Given this list of marker genes ULK1, CRLS1, MIPOL1, STRADB, TBC1D4, BMI1, KDM7A, CLTRN, IL1R1 (interleukin 1 receptor type 1, NCBI Gene Id 3554), CHM, FNTB, CA13, FOXJ3, CCR5, GALNT7, ATAD2B, CHORDC1, TET3, C2CD4A, KCNN3, PSD3, RAD52, IRF2BP2, LARP1, SLC2A3, PPP1R3D, ATOSB, BAG4, LNX2, SRGAP1, LMO3, OVOL2, CRCP, NSMCE2, MEAF6, UNC80, DICER1, PDE4B, STXBP5L, ZNF689, DHX35, RFESD, FRMD3, FA2H, CAPZA2, PALM3, MYPN, ATP2B1 (ATPase plasma membrane Ca2+ transporting 1), SEMA6D, PPP6R3, KLF7, SKIL, PAQR8, EML4, SIX4, OLIG3, EIF2S1, MLANA, ZNF532, MAGEE1, FERMT2, NCAM2, C12orf76, GJA1, DSN1, FUBP3, PSMA2, ESRP1, CREBL2, RFK, ZNF449, GPR171, DBF4, PGM2, DAB2, TMEM245, WDR26, PLEKHG1, YPEL2 (NCBI Gene Id 388403), SARAF (store-operated calcium entry associated regulatory factor), TENT4B, C5, ODC1, SKP2, TTC13, POLR2M, KDM6A, ZNF518A, PALM2AKAP2, MARCHF4, CREB1, STK39, U2SURP, SKI (SKI proto-oncogene), GSK3B, PHF6, PHF3, FAM200B, ETNK1 (NCBI Gene Id 55500), NAP1L3, MRFAP1, NOSTRIN, TMEM69, PTPN1, KIF5B, FAM98A, FAR1, TAFA2, KLHL18 (NCBI Gene Id 80077), GABRG2, BACH2, RAB28, LEP, YWHAG, TRABD2A, CIPC, SPIN4, DCLK1, CREBRF, RTN3, LRRC8C, AAK1, RHOQ, SYNPO2, RCBTB1, CUL4B, DENND4C, OSBPL11, REEP3, USF3, PRKAG2, DCBLD2, PLD5, PRTG, CDK6, RALA, ITSN1 (intersectin 1), FLVCR1, GCOM1, LPCAT2, FBN1, RSPH4A, KLHL42, EP300, DUSP4, MAPK6, NCOA1, PABIR1, PDE4DIP, CHD1, ZDHHC6 (NCBI Gene Id 64429), BEST3, RALGAPB, TET2, TRPC3, ZNF652, CD2AP, TFRC, SREK1 (splicing regulatory glutamic acid and lysine rich protein 1), EAF1, PCGF5, LINC02694, RNF11, PPM1A, CMPK1, GABRA4, WWOX, VAPA, GRIA3, EYA3, HIPK1, CACNA2D3, CD109, CCPG1, HBP1, TLL1, ZFP36L1, MORF4L2, MCTP1, MAB21L1, ALAD (NCBI Gene Id 210), DYRK1A, ZEB2, ATP5F1E, BIVM, YOD1, DDX4, GLMN, TMTC1, HOOK3, STYX, RANBP3L, ZBTB43, CILP, GPR107, SNRK, NEMF, RIPOR2, STRBP, PWWP3B, GNA13, GATM, ZNF70, COMMD3-BMI1, LIN28B, FBXO45, TET1 (NCBI Gene Id 80312), MED14, PPIP5K2, TMEM59, HS3ST2, PPP1R15B, NFIB, WT1, INSC, CHFR, PACSIN2, HSPA12A, MOB1B, FAM193A, ELAVL4, KCNT2, IRF2, COA7, MMAA, CREBBP, GCNT1, MATN3, PTPN4, RESF1, TIMM17A, PAM, RGS4, KLF6, TRIM71, POLQ, ONECUT2, FRAT2, NUDT19, NAB1, ATP11C, B3GNT2, SMIM13, MTRF1L, here is a description of the gene set: species: Homo sapiens Human Gene Set: MIR498_5P from publication Chen Y, Wang X (PMID 31504780) Genes predicted to be targets of miRBase v22 microRNA hsa-miR-498-5p in miRDB v6.0 with MirTarget v4 prediction scores > 80 (high confidence targets).